Given this list of marker genes BCL2L11, ADAM8, PTCRA, BBC3, BAX, BCL11B, HIF1A, CHEK2, KIFAP3, DFFA, RORC, GLI3, BAK1, JAK3, TP53, RAG1, WNT5A, ADA, BMP4, EFNA1, ZC3H8, here is a description of the gene set: Any apoptotic process in a thymocyte, an immature T cell located in the thymus. studied in species Homo sapiens Human Gene Set: GOBP_THYMOCYTE_APOPTOTIC_PROCESS